The following is a description of a gene set: Human Gene Set: GOBP_ADENYLATE_CYCLASE_INHIBITING_G_PROTEIN_COUPLED_GLUTAMATE_RECEPTOR_SIGNALING_PATHWAY An adenylate cyclase-inhibiting G protein-coupled receptor signaling pathway initiated by glutamate binding to its receptor, and ending with the regulation of a downstream cellular process. studied in species Homo sapiens, and this is the list of marker genes: GRIK3, GRM7, GRM2, GRM4, GRM5, GRM6, GRM3, GRM8, GRM1